The following is a description of a gene set: Reactome Pathway: RAS GTPase cycle mutants RAS proteins cycle between an active GTP-bound state and an inactive GDP-bound state. GTPase activating proteins (GAPs) stimulate the low intrinsic GTPase activity of RAS proteins, converting the active to the inactive form, while guanine nucleotide exchange factors (GEFs) stimulate the intrinsic dissociation of GDP, allowing its replacement with GTP and consequent activation of RAS. Disease-causing mutations in RAS promote constitutive signaling by favouring the accumulation of RAS:GTP. The vast majority of these mutations are loss of function mutations at G12, G13 and Q61. These mutations disrupt the GTPase activity of RAS proteins by interfering with nucleophilic attack on the gamma phosphate of GTP. A smaller proportion of RAS mutations increase the intrinsic GDP dissociation rate, while other mutations interfere with RAS interactions with GAPs. part of: Signaling by RAS mutants studied in species Homo sapiens, and this is the list of marker genes: NRAS, KRAS, HRAS